Given this list of marker genes ARHGAP32, ACTC1, EPS15, CTSB, PSMC5, VCL, CTBP2, SNAI2, PSMB6, PSMD6, H2AC6, MIR10B, SNAI1, CSNK2A3, EZH2, AGO1, FOXQ1, CTSL, PSMC6, PRKCSH, CTNNA1, PSMD1, ACTA2, ZNF217, TMEM258, H2AX (NCBI Gene Id 3014), H2BC14, PSMD8, H2BC11, MCRIP1, FYN, PSMA3, SMARCA4, GANAB, H2BC4, TCF3, TNRC6A, ZBTB33, CTNND1, OST4, ACTG2 (NCBI Gene Id 72), H2BC3, SUZ12, MOV10, PSMA7, H2BC12L, PCSK6, SP1, CTNNB1, TCF12, MIR9-2, SPCS3, UBA52, RPS27A, H2BC21, PSMD13, H2AC20, FURIN, CDH1, PSMD11, PSMC1, ACTA1, H2BC12, JUP, PCSK7, MIR9-3, PSMA6, EED, ARID1A, H3-3A, H4C1, H2BC5, MPHOSPH8, H3C1, KLF4, DNM2, PSMD7, MIR9-1, H2BC9, MDM2, AGO4, ACTG1, ZEB2, KLF9, H2AC7, SIRT1, PKM, FOXP2, POMT2, H2AC4, TGIF2, PIP5K1C, AGO3, PSMD3, MAPK3, CSNK2A2, PSMD12 (proteasome 26S subunit, non-ATPase 12), H2BC13, MAPK1, DAD1, PSMB5, MOGS, AGO2, STRAP, MTBP, UCA1 (NCBI Gene Id 124900418), H2AB1 (H2A.B variant histone 1), DDOST, TNRC6C, RB1, SPCS2, PSMA2, PSMB4, SRC, STT3A, PSMC4 (NCBI Gene Id 5704), MYCN, FOXJ2, TFAP2A (NCBI Gene Id 95131), CSNK2B, CTBP1, PSMB1, RPN1, PSMB3, PSMC3, H2BC17, PSMB7, TWIST2, HDAC2, H2AC14, RACK1, H2BC1, ZEB1, SPCS1, RPN2, KDM1A, CSNK2A1, MYC, CTSS, RBBP4, PSMD2, WT1, OSTC, TWIST1, H2AZ2, HDAC1 (histone deacetylase 1), ACTB, PSMA4, PSMA1, CANX, CBLL1, RBBP7, DNTTIP1, PSMC2, PSMD14, H2BC26 (H2B clustered histone 26), PSMB2, SEM1, SEC11C (SEC11 homolog C, signal peptidase complex subunit), UBC, H2AJ, PSMA5, POMT1 (protein O-mannosyltransferase 1), ANK3, H2AC18, UBB, H2BC15, SEC11A, TNRC6B, BANP, ADRM1, FOXA2, H3C15, ZMYM2, KMT5A (lysine methyltransferase 5A), TLE1, here is a description of the gene set: Reactome Pathway: Regulation of Expression and Function of Type I Classical Cadherins <p>The cadherin superfamily is made of transmembrane glycoproteins involved in calcium-dependent cell-cell adhesion and cell-cell recognition. The human type I subfamily of classical cadherins includes CDH1 (E-cadherin), CDH2 (N-cadherin), CDH3 (P-cadherin), CDH4 (R-cadherin), and CDH15 (M-cadherin). Like other classical cadherins, Type I cadherins possess five extracellular cadherin domains (EC1-5), which drive cell-cell adhesion through formation of trans-dimers, usually trans-homodimers (also known as homotypic dimers), between two identical cadherin molecules expressed on plasma membranes on two adjacent cells. Type I classical cadherins contain a conserved tryptophan residue at the second position of their EC1 domain, while Type II cadherins contain two conserved tryptophan residues at positions 2 and 4 of their EC1 domain. These tryptophan residues directly participate in formation of cadherin trans-dimers. Type I cadherin also contain a conserved diproline motif, with two proline residues at position 5 and 6 of their EC1 domain. The diproline motif increases the specificity of Type I cadherins for binding identical cadherin molecules, thus favoring formation of homotypic dimers, while Type II cadherins also engage in formation of heterotypic dimers.</p><p>Homotypic trans-dimers of CDH1, also known as epithelial cadherin, are a central complex in adherens junctions of polarized epithelia. Loss-of-function missense mutations in CDH1 are an underlying cause of about 30% of cases of hereditary diffuse gastric cancer (HDGC), and a polymorphism in CDH1 gene promoter has also been associated with increased gastric cancer risk. CDH1 is frequently downregulated in tumors of epithelial origin and is considered to be a tumor suppressor gene. Loss of CDH1 expression promotes epithelial-to-mesenchymal transition (EMT), implicated in tumor invasiveness.</p> studied in species Homo sapiens part of: Regulation of Homotypic Cell-Cell Adhesion